The following is a description of a gene set: species: Mus musculus Mouse Gene Set: CUI_T_CELL_CD8_TSLP_RESPONSE_DN Cytokines mediate cell-cell communication in the immune system and represent important therapeutic targets. A myriad of studies have highlighted their central role in immune function, yet we lack a global view of the cellular responses of each immune cell type to each cytokine. To address this gap, the authors created the Immune Dictionary, a compendium of single-cell transcriptomic profiles of more than 17 immune cell types in response to each of 86 cytokines (>1,400 cytokine-cell type combinations) in mouse lymph nodes in vivo. A cytokine-centric view of the dictionary revealed that most cytokines induce highly cell-type-specific responses. For example, the inflammatory cytokine interleukin-1β induces distinct gene programmes in almost every cell type. A cell-type-centric view of the dictionary identified more than 66 cytokine-driven cellular polarization states across immune cell types, including previously uncharacterized states such as an interleukin-18-induced polyfunctional natural killer cell state. Genes negatively differentially expressed in cell type: CD8+ T cell upon treatment with cytokine: TSLP in mouse lymph nodes in vivo. from publication Cui A, Huang T, Li S, Ma A, Pérez JL, Sander C, Keskin DB, Wu CJ, Fraenkel E, Hacohen N (PMID 38057668), and this is the list of marker genes: Ccl5, Hspa1a, Jak1, Il7r, Uba52